The following is a description of a gene set: species: Homo sapiens Genes down-regulated in comparison of unstimulated CD8 T cells at 24 h versus CD8 T cells at 24 h after treatment with trichostatin A (TSA). from publication Agarwal P, Raghavan A, Nandiwada SL, Curtsinger JM, Bohjanen PR, Mueller DL, Mescher MF (PMID 19592655) Differentiation of naive CD8 T cells into cytotoxic effector cells requires three distinct signals- antigen (signal 1), costimulation -B7-1 (signal 2) and cytokine, either interleukin-12 or interferon-a/b (signal 3). Interaction of naive CD8 T cells with antigen and B7-1 programs cell division and proliferation whereas the presence of cytokines- IL-12 or IFNa/b promote survival, differentiation and memory establishment. In the absence of signal 3, the cells interacting with antigen/B7-1 undergo tolerance induction. The objective of this study was to elucidate the mechanisms how the provision of signal 3 promotes differentiation and averts tolerance induction in CD8 T cells. Trichostatin A is a pharmacological agent that inhibits histone deacetylase activity, hence regulating chromatin structure and gene expression and differentiation in many cell types. Gene signature profiles of IL-12, IFNa/b and trichostatin A stimulated cells were compared to elucidate the molecular mechanisms of gene regulation. Oligonucleotide microarray analysis is carried out to determine the extent and molecular nature of the CD8 T cell differentiation program induced by IL-12 or IFNa/b in concert with antigen and B7-1 signal. Human Gene Set: GSE15930_STIM_VS_STIM_AND_TRICHOSTATINA_24H_CD8_T_CELL_DN, and this is the list of marker genes: ECPAS (NCBI Gene Id 23392), NUSAP1, SMARCB1, PPIE, GNB1, PLG, IRF7, FRAT1, CISH, DIAPH1, CWC15, LUC7L3, KMT2E, DDX19A, VAPA, TPRG1L, RACK1, TSR1 (NCBI Gene Id 55720), WDR46, MORC4, RBM26, SIX5, SLC20A1 (solute carrier family 20 member 1), FKBP1A, THAP7, GALK2, KPNA6, SEPTIN7, SEC23A, DVL2, MEF2D, SLMAP, PRPF8, CDV3, SYNGR2, CCL4, LITAF, KIF3B, UBE2A, GLRB, POLR3D, SLC25A28, COQ9, COASY, RER1, HSD17B11, PDCD2, SPATA13, POLR2J, ZSCAN26, RPA3, AFG2A, KTN1, UBE2N, SYT7, SLC38A4, CLPTM1L, PTPN23, RIOX2, CD70, TMT1A, TEKT2, HAND2, OGFOD2, SYNRG, FOLR2, TANK, CMA1, FOSB, TSPAN5, SP3, ZNF274, GCH1 (NCBI Gene Id 93984), FZD6, DCAF13, TCEA1, CCDC6, SON, OTULINL, MAPKAPK5, LY75, SEPHS2, POLR3A, MRTO4, KLF4, PRMT1, CCKAR, CPSF7, COX7A1, DDX39B, FBXO38, PIP4K2C, SEPTIN10, NFE2, SLU7, PEPD, RNF34, MRPS7, TPT1, ENO1, DDX10, E2F5, SCN1A, ZNF638, UBE2S, MRPS14, IMPA1, SEPTIN2, S1PR1, RNASEH1 (NCBI Gene Id 246243), PRSS58, NAB1, RERE, VMP1, PNLIPRP1, SNX2, FKBP10, FIP1L1, CHPT1, INTS8, RAB5A, SPICE1, DPF3, ROCK2, NRCAM, SEPTIN4, VEGFA, MBD4, MRPS25, PEMT, PSMC1, COPS3, ELAVL4, SRSF9, TIMM8A, LEPROT, SGPP1, SELENOK, KCNK3, INHBC, RASA4, MIX23, MXI1, TYSND1 (trypsin like peroxisomal matrix peptidase 1), COPZ1, IFIT3, SMAP1 (small ArfGAP 1), HTR2C, MOGAT2, MSH3, WDHD1, SPIN1, DNAJB2, SEC11A (SEC11 homolog A, signal peptidase complex subunit), INPP1, UBA7, MTARC2, SCP2, NQO1, HLA-DOB, METTL17, G0S2 (NCBI Gene Id 50486), TNFRSF9, CCND1, NFU1, DMRT1, IKBKB, PGAM1, SWAP70, OGT, MRPS18B, P2RX6, S100PBP, MTHFR, GRPEL2, PTPN18, POLR2H, SMAD2, IFIT2, DCUN1D5, TSFM, IL10RA, MFSD14A, RUNX1T1, MLLT1, IREB2 (NCBI Gene Id 3658), TTK, TM9SF2, MSRB1, RIPOR2, EEF1AKMT1, RBBP4, RMND1, NEDD8, PGM1, DEK, POP4, CTSC, LRPPRC, NCOA2